The following is a description of a gene set: Mouse Gene Set: GOBP_VESICLE_LOCALIZATION species: Mus musculus Any process in which a vesicle or vesicles are transported to, and/or maintained in, a specific location., and this is the list of marker genes: Tmed9, Cep19, Unc13c (unc-13 homolog C), Snf8, Fam91a1, Cdk5, Lin7c, Rab3a, Unc13a, Trak2, Myo1c, Cdh2, Vps33b, Arfgap2 (ADP-ribosylation factor GTPase activating protein 2), Spg11, Exoc7, Atp13a2, Eipr1, Ahi1, Ikbkg, Cdh3, Baiap3, Vps4a, Mlph, Ap1s2, Cnih2 (NCBI Gene Id 12794), Syn1, Pef1, F8a, Trappc3, Ap1ar, Tanc2, Vps33a, Dync1i1 (NCBI Gene Id 209813), Ndel1, Lin7b, a, Trappc12, Syt4, Tcirg1, Exoc5, Pten, Slc2a4, Fnbp1l, Wasl, Sar1b, Unc13d, Mx2, Hgs, Rab3gap1 (RAB3 GTPase activating protein subunit 1), Rab17, Sdc1, Stxbp2, Map4k2, Snapin, Exoc1, Bicdl2, Exoc6, Clasp1, Fgfr2, Dnm2, Exoc4, Hap1, Mecp2, Ap3s1, Trappc11, Pafah1b1, Myo5c, Bloc1s4, Dnm1, Trappc13, Kif5c, Cadps2, Ap3b1, Exoc6b, Scrib, Htt, Ap3s2, Trappc5, Nlgn2, Cln3, Kifc2, Prkcz, Ppfia2, Kif5a, Wipi1, Tesk1, Smpd3, Fyco1, Dnm3, Tcf7l2, Mreg, Rab1a, Ap3d1, Pdcd6, Kif1a, Ccdc186, Trappc4, 5730455P16Rik, Rab11a, Magi2, Bcl2l1, Itga4, Pdcd6ip, Dipk2a, Trappc10, Ap3m1, Myo5a, Sdcbp (NCBI Gene Id 53378), Kif16b, Exoc2, Borcs5, Sybu, Syndig1, Tmed10, Unc13b, Trappc2l, Bloc1s2, Tbc1d23, Uso1, Trappc9, Syn2, Nde1, Preb, Bloc1s1, Rab7, Btbd8, Picalm, Cadps, Pclo, Tsg101, Prkn, Dtnbp1, Dpysl2, Kif1c (kinesin family member 1C), Clasp2, Actn4 (actinin alpha 4), Map2, Trappc1, Exoc8, Synj1, Kifc1, Ctnnb1, Myo1a, Myrip, Mapk8, Sdc4, Bloc1s5, Ap3m2, Vps4b, Kif1b, Lin7a, Wdr11, Dctn1, Mapk15, Snap25, Pik3cg, Arf1, Trappc6b, Trappc6a, Snca, Stard3, Trak1, Stk11, Mylk2, Tmed10-ps, Syt11, Stard3nl, Cops5, Myo7a, Sec16a, Bloc1s3, Limk2, Arfgap3, Stxbp1, Bloc1s6, Naglu, Pcdh17, Stam, Klhl12, Kif13a, Syn3 (NCBI Gene Id 27204), Gbf1, Trip11, Chp1, Madd, Stxbp3, Rab11b, Steap3, Dctn2, Tor1a, Syt10 (synaptotagmin X), Psen1, Ykt6, Kif28, Myo5b, Lrrk2, Exoc3, Tpgs1, Map2k1, Bicdl1, Syt6, Kif5b, Nlgn1, Shroom2, P2rx7, Chmp2a, Fbxw11, Trim46, Ctbp1, Gpr143, Bsn, Snap91, Tmem230, Pdzd11, Nlgn3, Ap3b2, Atp9a, Sar1a, Cul3, Rasgrp1, Rab27a, Rims1, Trappc2, Nrxn1